The following is a description of a gene set: Atrophy/Degeneration involving the spinal cord Human Gene Set: HP_ATROPHY_DEGENERATION_INVOLVING_THE_SPINAL_CORD studied in species Homo sapiens, and this is the list of marker genes: CYP7B1 (NCBI Gene Id 9420), MMACHC, PI4KA, ABCD1, NEFL, FA2H, SPG11, CCT5, DNAJC3, MTHFR (NCBI Gene Id 4524), GFAP, ALDH18A1, POLG, LYST, MORC2, SPG7, SETX, TWNK, PNPLA6, FXN, LMNB1